The following is a description of a gene set: Mouse Gene Set: MIR_7243_5P studied in species Mus musculus Genes predicted to be targets of miRBase v22 microRNA mmu_miR_7243_5p in miRDB v6.0 with MirTarget v4 prediction scores > 80 (high confidence targets). from publication Chen Y, Wang X (PMID 31504780), and this is the list of marker genes: Tslp, Jph1, Tnni3k, Msl3l2, Scrt2, Mmp12, Hipk1, Ddx19b, Scaf11, Ube2g2, Rnf26, Crhr1, Samd4b, Rinl, Car12, Tnfrsf18, Bpifb9a, Tbl1xr1, Sult1e1, Hnrnpa3, Ubr5, Bcl11a, Tmem230, Oprd1, Gask1b, Apobec1, Tek, Alcam, Phyhip, Aak1, Tent5a, Nfya, Trpc1, Npr3, Galnt17, Dixdc1, Man1a, Mob1a, Inpp4b, Gpr179, Slfn8, Mex3d, Hira, Slc52a2, Dgkb, Carm1, Adamts5 (ADAM metallopeptidase with thrombospondin type 1 motif 5), Tmem47 (transmembrane protein 47), Slf1, Zbtb1, Cpsf4l, Fam47e, Traf3, Btn1a1, Rnf224, Mycbp, Tmem255a, Cdkn2aip (CDKN2A interacting protein), Cdh13, Bpifb9b, Osbp, Trim9, Helz (NCBI Gene Id 78455), Olfm3 (olfactomedin 3), Cadm2, Gask1a, Glipr2